The following is a description of a gene set: part of: Cargo trafficking to the periciliary membrane Reactome Pathway: VxPx cargo-targeting to cilium A number of membrane proteins destined for the ciliary membrane are recognized by ARF4 in the trans-Golgi network, initiating the formation of a ciliary targeting complex that directs the passage of these cargo to the cilium. Although there is some support for the presence of a VxPx or related motif in the C-terminal tail of cargo destined for ARF4-mediated transport to the cilium, the details of this have not been definitively established and other ciliary targeting sequences have also been identified. studied in species Homo sapiens, and this is the list of marker genes: GBF1 (golgi brefeldin A resistant guanine nucleotide exchange factor 1), RAB3IP, EXOC6, RAB11A, EXOC2, CNGA4, EXOC5, RAB8A, ASAP1, EXOC8, PKD1, RAB11FIP3, EXOC4, PKD2, EXOC3, CNGB1, ARF4, CNGA2, RHO, EXOC1, EXOC7